The following is a description of a gene set: Human Gene Set: REACTOME_PHENYLALANINE_METABOLISM Phenylalanine metabolism species: Homo sapiens, and this is the list of marker genes: PAH, IL4I1, ASRGL1, KYAT1, PCBD1, QDPR